The following is a description of a gene set: Human Gene Set: GOBP_POSITIVE_REGULATION_OF_WNT_SIGNALING_PATHWAY studied in species Homo sapiens Any process that activates or increases the frequency, rate or extent of Wnt signal transduction., and this is the list of marker genes: MIR29B1, POU5F1, EDA, SULF1, SOX4, ADNP, SFRP1, SALL1, MIR501, WLS, RNF146, TTC21B, MIR183, PLEKHA4, PIN1, SULF2, EGF, CTDNEP1, FGFR2, MESD, NLE1, PPM1B (protein phosphatase, Mg2+/Mn2+ dependent 1B), CAPRIN2, CRBN, NFKB1, RUVBL1, SPIN4, MIR1260B, TLR2, LYPD6, SFRP4, TRPM4, XIAP, CCAR2, SCEL, ATP6V0C, LBX2 (ladybird homeobox 2), BMP2, LRRK1, ATP6AP2, FGF10, EGFR, ATP6V1C2, PCDH11Y, CSNK1D, KANK1, SEMA5A, BIRC8, ZRANB1, LGR6, LGR4, WNT3A, DISC1, SRC, PRDM15, USP47, TMEM9, FRAT1, TERT, WNK1, SMARCA4, USP34, USP8, SHH, UBE2B, ZEB2, WNT3, DAAM2, DIXDC1, CSNK1E, COL1A1, VCP, CCN4, SMAD3, PPM1A, TNKS2, MLLT3, MIR346, SFRP2, RSPO2, DKK2, BMAL1, DKK1, GSKIP, FGF2, GPC3, CSNK1G2, PPP2R3A, NRARP, DAPK3, ADGRA2, AMER1, WNT10B, TMEM198, SKI, CSNK1G1, SPIN1, RNF220, SMURF2, LEF1, YAP1, CSNK1G3, DLX5, FAM53B, JUP, RPS12 (ribosomal protein S12), WNT5B, LRRK2, DAB2, RSPO1, LGR5, CCDC134 (coiled-coil domain containing 134), UBR5, GID8, ABL1, PTK7, MBD2, RSPO4, FGF9, PPM1N, WNT5A, TNKS, DACT1, ASPM, HHEX, RECK, CDC73, ZBED3, BAMBI, WNK2, DEPDC1B, CDH3, GPRC5B, MIR26A1, HSP90B1, JRK, VPS35, RSPO3, TBL1XR1, TBL1X, RBPJ, FZD9, TMEM132A, PBXIP1, MIR145, DDX3X, TGFB1, SBNO1, MACF1, GPC5, NKD1, ANKRD6, CSNK2A1, TNFAIP3, ILK